Given this list of marker genes ERCC4, MCRS1, POT1, TERT, TERC, TEP1, TERF1, TERF2, PIF1, PTGES3 (NCBI Gene Id 10728), PINX1, TEN1, ACD, DKC1, here is a description of the gene set: Catalysis of the reaction: a 2'-deoxyribonucleoside 5'-triphosphate + DNA(n) = diphosphate + DNA(n+1) using an internal RNA template that encodes the telomeric repeat sequence. studied in species Homo sapiens Human Gene Set: GOMF_TELOMERASE_ACTIVITY